The following is a description of a gene set: Genes up-regulated in bone marrow-derived macrophages with MLL4 knockout: control versus treated with LPS for 4h. Human Gene Set: GSE30971_CTRL_VS_LPS_STIM_MACROPHAGE_WBP7_KO_4H_UP Histone methyltransferases catalyze site-specific deposition of methyl groups, enabling recruitment of transcriptional regulators. In mammals, trimethylation of lysine 4 in histone H3, a modification localized at the transcription start sites of active genes, is catalyzed by six enzymes (SET1a and SET1b, MLL1–MLL4) whose specific functions are largely unknown. By using a genomic approach, we found that in macrophages, MLL4 (also known as Wbp7) was required for the expression of Pigp, an essential component of the GPI-GlcNAc transferase, the enzyme catalyzing the first step of glycosylphosphatidylinositol (GPI) anchor synthesis. Impaired Pigp expression in Wbp7-/- macrophages abolished GPI anchor-dependent loading of proteins on the cell membrane. Consistently, loss of GPI-anchored CD14, the coreceptor for lipopolysaccharide (LPS) and other bacterial molecules, markedly attenuated LPS-triggered intracellular signals and gene expression changes. These data link a histone-modifying enzyme to a biosynthetic pathway and indicate a specialized biological role for Wbp7 in macrophage function and antimicrobial response. studied in species Homo sapiens from publication Austenaa L, Barozzi I, Chronowska A, Termanini A, Ostuni R, Prosperini E, Stewart AF, Testa G, Natoli G (PMID 22483804), and this is the list of marker genes: IL36G, IL10, DCUN1D3, BATF, BCL2A1, KCNJ2, SLC1A2, IL19, GPR137B, CPM, NKX3-1 (NCBI Gene Id 4824), PLAT, CNKSR3, MIR3945HG, MAML2, SIGLEC15, MFSD2A, KBTBD2, CEMIP, IL6, SVIL, PDE8A, MCEMP1, GJB2, SMPDL3A, GRAMD2B, CDC42EP3, UPP1 (uridine phosphorylase 1), MAP7, NPC1, SLC2A3, SEC24B, TNFRSF9, FSD1L, LIMK2, HDAC9, PTEN, HEY1, IL12B, BAALC, TRAF3IP2, GK, TBC1D30, EIF1B, GFPT2, CTSL, TNF (NCBI Gene Id 7124), RGS16, ZC3H12A, ZBTB43, MCOLN2, STK26, STAT3, TM4SF1, PLD1, TBC1D9, TGFA, PAPSS2, OSGIN2, LCOR, GNG2, PLAC8, ACSL5, ELL2, CISH, ENPP4, HAS1, C11orf96, ACOD1, GADD45B, FLT1, UBE2B, RBM17, CD274, SLCO4A1, SLC25A37, PLGRKT, STEAP1, SOCS2, ADGRE1, SOCS1, AGO2, STRIP2 (striatin interacting protein 2), SAMTOR, FERMT2, CCL1, SOCS3, BASP1, ZNF319, CCL23, TNFRSF1B, ARHGAP24, OTUD1, SERPINB9P1, MET, IL1A, AGPAT4, ELOVL7, STAT4, AQP9, PTX3, SCARF1, CT75, NEDD4L, CRACD, ATF7IP, TRIM36, RFTN1, AGFG1, CHM, GK5, MSANTD3, ABCA1, AKT3, ITGB8, FJX1, BCAT1, ASAP2, MPZL1, VNN3P, HRH1, EZH2, SLC11A2, HES1, LINC01093, SGPP2, LRIG1, NFKBIA, SERPINB1, MTF1, MTHFS, SAMD8, PIM1, NUP58, TRIP10, IRAK3, AZIN1, EHD1, PTGS2, GRAMD1A, USP12, SLAMF1, CCL18, WTAP, F3, NFAT5, ZBTB10, CLGN, SFR1, SMS, MAP3K5, CTSLP8, LPP-AS2, PIK3AP1 (phosphoinositide-3-kinase adaptor protein 1), SLC7A7, CSF3, IL2RA, PFKFB3, MRPL52, IER5, TAB3, SLC16A10, SERPINB7, PPP1R3B, ADAM19, NDP (norrin cystine knot growth factor NDP), IER3, TMEFF1, FPR2, MYO10, MIR155HG, PHLDA2, TNIP3, TNFSF15, RASSF8 (NCBI Gene Id 11228, Ras association domain family member 8), TNFAIP6, ETS2, CCDC93, P2RY2, ABHD17C, MAP3K4, TMEM39A, TP53BP2, MAP3K20, MIR9-1HG, SAV1, PLAGL2, LAMB3, OSBPL8, ANKRD33B (ankyrin repeat domain 33B), PDSS1, KANK1 (NCBI Gene Id 23189), ACVR1B, YRDC, PNPLA8, DLL1